Given this list of marker genes Epha4, Ngef, C1qb, C1qc, Cx3cr1, C1qa, Plxnc1, Itgam, C3, Sarm1, Cdk5, C1ql1 (NCBI Gene Id 23829), Itgb1, Adgrb3, Kcnk13, Cd47, Vangl2, Trem2, here is a description of the gene set: Mouse Gene Set: GOBP_SYNAPSE_PRUNING studied in species Mus musculus A cellular process that results in the controlled breakdown of synapse. After it starts the process is continuous until the synapse has disappeared.